Given this list of marker genes SREK1, DLG2, CLPB, RAB30, STRN3, ARCN1, RMI1, WDR13, ADGRL1, MCTS1, TET2 (NCBI Gene Id 57667), AP4S1, COL1A2, ACTR8, PAFAH1B1, SYNCRIP, BCL2L1, SFPQ, OR3A2, TOMM40L, UBE4B, PIGA, SLC12A8, KBTBD12, GNL3L, NASP, CD164, ATP6V0C, TMEM187, ADNP, CSRNP3, RPS8, SMYD5, NCOA5, SLC39A7, SLC39A9 (NCBI Gene Id 55334), FBXO9, ESCO1, IGF1R, HOXD4, ADAM11, RPL4, EBAG9, ESRP2, RGS3, SFXN1, SNPH (NCBI Gene Id 9751), KIF1B, RXRB, PPP1CC, ZNF362, RNF145, NIM1K, NSD3, ARID1A, EIF4G2, EPC1, BRD2, ABRAXAS2, PUM1, NFYC, PSMD8, CREBRF, TTC9C, ELAPOR1, RPL18A, ITSN1, STAG1, ITCH, HMGN2, CD4, SOCS5, OARD1 (O-acyl-ADP-ribose deacylase 1), SPRY4, OSR1, CRYZL1, TOB2, CNBP, TYRO3, NSD1, RBM39, KLHDC8B, RPL32, MATR3, POU2F1, CNST, FAXC, GEMIN4, HNRNPK, TXNDC12, MIOS, VAMP2, DYM (NCBI Gene Id 54808), PATL1, CHTOP, HNRNPA3, TFB2M (transcription factor B2, mitochondrial), DPYSL2, ARID4A, ERH (NCBI Gene Id 95660), KMT2E, EIF4A1, RAD21, HOXA2, RAB1A, PHF21B (NCBI Gene Id 50609), NFYA, RALA, RBM26, ZIC3, PIGV, PDLIM2, ZBTB40, CCDC71, NRBP2, RPS27, ZWILCH, SAR1B, YBX1, CREB3L1, LUC7L3, here is a description of the gene set: species: Homo sapiens Comprehensive identification of all functional elements encoded in the human genome is a fundamental need in biomedical research. Here, we present a comparative analysis of the human, mouse, rat and dog genomes to create a systematic catalogue of common regulatory motifs in promoters and 3' untranslated regions (3' UTRs). The promoter analysis yields 174 candidate motifs, including most previously known transcription-factor binding sites and 105 new motifs. The 3'-UTR analysis yields 106 motifs likely to be involved in post-transcriptional regulation. Nearly one-half are associated with microRNAs (miRNAs), leading to the discovery of many new miRNA genes and their likely target genes. Our results suggest that previous estimates of the number of human miRNA genes were low, and that miRNAs regulate at least 20% of human genes. The overall results provide a systematic view of gene regulation in the human, which will be refined as additional mammalian genomes become available. from publication Xie X, Lu J, Kulbokas EJ, Golub TR, Mootha V, Lindblad-Toh K, Lander ES, Kellis M (PMID 15735639) Genes having at least one occurrence of the highly conserved motif M88 GGCNKCCATNK in the regions spanning 4 kb centered on their transcription starting sites. The motif does not match any known transcription factor binding site. Human Gene Set: GGCNKCCATNK_UNKNOWN